The following is a description of a gene set: Binding to a PDZ domain of a protein, a domain found in diverse signaling proteins. species: Mus musculus Mouse Gene Set: GOMF_PDZ_DOMAIN_BINDING, and this is the list of marker genes: Grip1, Exoc4, F11r, Tgfbr3, L1cam, Cadm1, Map2k2, Nkd1, Adrb1 (NCBI Gene Id 11554), Slc26a6, Sdc2, Grin2c, Adgrb1 (adhesion G protein-coupled receptor B1), Pdzk1 (PDZ domain containing 1), Ccdc88c, Arhgef16, Fzd7, Atp2b1, Nherf1, Muc17, Gopc, Rapgef2, Crim1 (cysteine rich transmembrane BMP regulator 1), Lnx2, Cript, Adgrl2, Fzd2, Slc22a4, Dtna, Cntnap2, Gng12, Prkn, Musk, Gng5, Nsf, Phaf1, Fzd1 (frizzled class receptor 1), Dmd, Shisa9, Dlg3, Kcnj4, Gja1, Kidins220, Psen1 (presenilin 1), Abtb3, Sntb1, Tmem88, Ctbp1, Pten, Dlg4, Slc22a12, Grid2, Slc9a3, Erc2, Plekha2, Lrp2, Sntg2, Lin7b, Apba1, Mpp3, Fzd3, Tbc1d10a, Clcn3, Grm7, Tcf3, Kif14, Lzts3, Cntnap4, Synj2, Dlgap3, Dlg1, Cit, Atp2b2, Lin7c, Kirrel3, Plekha1, Nos1ap, Mpp2, Arhgap29, Atp2b4, Cldn16, Grik5, Sstr2, Cftr, Lnx1, Nlgn1, Srr, Atp2b3, Gipc1, Fzd8, Llgl2, Lpar2, Fzd4, Dock4, Ushbp1, Shisa6, Slc34a1, Cxadr, Grik2, Cxxc4, Tamalin, Cacna1d, Adam17, Slc22a5, Gria1, Gria2, Snta1, Aqp2, Dlg2, Cacng3, Lin7a, Hcn2, Lpar1, Kcnj12, Kcnj9, Cask, Baiap2, Erc1, Acox1, Acvr2a (NCBI Gene Id 11480), Igsf5, Rps6kb1, Gpr37, Slc22a21